The following is a description of a gene set: The process whose specific outcome is the progression of sensory organs over time, from its formation to the mature structure. Mouse Gene Set: GOBP_SENSORY_ORGAN_DEVELOPMENT studied in species Mus musculus, and this is the list of marker genes: Rrm1, Egfr, Inhbb, Gja1, Mfap2, Wnt10a, Limk2, Acvr2b, Prss56, Ftx, Hoxa13, Pax8, Dlx1, Krt13, Slc38a8, Abi2, Bfsp1, Agtpbp1, Mfap5, Tbc1d32, Sox4, Dicer1, Chrdl1 (chordin-like 1), Mir218-1, Tomt, Pbx4, Bcar3, Jmjd6, Frem2, Hpca (NCBI Gene Id 15444), Smoc1, Tulp1, Ift172, Gjb6, Prrx2, Kcnma1, Bloc1s5, Dll4 (NCBI Gene Id 54485), Igf1, Bcl11b, C1qtnf5, Dll1 (NCBI Gene Id 13388), Pax4 (NCBI Gene Id 18506), Dvl3, Tcap, Scrib, Mfrp, Tcf15, Wnt5a, Grhl3, Kdr, Fgf10, Pcdh15, Rd3, Bmp7, H2-T23, Lrig3, Hand2, Mafb, Tifab, Rpgr, Foxf2, Spred3, Rpl38, Pou4f2, Slc1a1, Ptf1a, Gli2, Lhfpl5, Prdm1, Lin7a, Tshr, Adam10, Blvra, Alms1, Lhx1 (NCBI Gene Id 16869), Itga8, Cdkn1c, Ttc39c, Vhl, Barhl2, Hoxa2, Sp3, Lamc3, Hmx3, Rpe65, Hsf4, Pdzd7, Ski, Kcnq4, Myo15a, Fzd2, Gjb2, Gdf11, Otogl, Mks1, Aqp1, Crygn, Foxc1, Thrb, Tfap2b, Ptprq, Nipbl, Tmod1, Nkx2-6, Gje1, Megf11, Nrl, Vax1, Chrna10, Tub, Olig3, Naglu, Slc26a5, Rubie, Gsdme, Neurog1, Rp1l1, Rarg, Usp45, Tspan12, Col4a1, Foxl2, Neurod4, Hcn1, Ptn, Cldn19, Calb1, Foxg1, Spry1, Epha2 (Eph receptor A2), Mitf, Klf4, Elmod3, Rorb, Tprn, Otx1, Slc17a8, Ihh, Ptpn11, Alg10b, Myo7a, Apc, Zfp513, Arhgap35, Ripor2, Gsc, Tgif1, Phactr4, Lgr5, Cntf, Cryba4, Hey2, Mapk1, Ift27, Bsg, Ccm2, Atp8a2, Foxn4 (NCBI Gene Id 243222), Slc25a25, Epha4, Rbpj, Gata2, Cys1, Gfi1, Mir23a, Miat, Nectin3, Edn1, Ror1, Fgfr1, Nkx2-5, Maf, Casp2, Hipk1, Mycn, Krtap21-1, Ift140, Adamts18, Clrn2, Fjx1, Myo3a, Ikzf1, Phox2b, Unc45b, Cryab, Pitx2, Abcb5, Irx5, Whrn, Jag2, Notch1, Mip, Hes1, Ush2a, Grn, Crygb, Cyp1a1 (NCBI Gene Id 13076), Sdk1, Smarcd3, Bhlhe22, Mir24-1, Prrx1, H2-DMa (NCBI Gene Id 14998), Nphp1, Mterf4, Kdm5b, Pde6a, Nphp4, Fasl, B9d1, Slc17a6, Yy1, Bmper, Rpgrip1l, Tfap4, Frzb, Chd7, Pde6b, Cryga, Sox1, Ptprm, Samd7, Foxp2, Irx6, Six5, Trpm1, Gnb1, Pdgfra, Rest, Gpd2, Hmx2, Grxcr2, Atp2b2, Scaper, Pou3f4, Sobp, Tmem231, Impg2 (interphotoreceptor matrix proteoglycan 2), Ifi204, Atf4, Gabra5, Pou2f1, Vegfa, C1qb, Atp2b4, Crybg3, Mfsd8, Pxdn, Gngt1, Gata3, Smg9, Jag1, Igfbp7, Plppr4, Hoxa1, Eya1, Myh10, Spry2, Fkbp8, Ret, Pcnt, Birc7, Efemp1, Pde6c, Bhlha15, Nhs, Ndp, Crygd, Pax6, Get1, Casz1, Wdpcp, Rxra (retinoid X receptor alpha), Atoh1, Man2a1, Dlx5, Bcl2l11, Insig2, Crb2, Nfia (nuclear factor I/A), Neurog3, Tbx18, Bmpr2, Skil, Psen1, Fbn1, Atoh7, Ntf5, Drd2, Crybb3, Wnt1, Arl6, Kcnk2, Fat4, Mertk (NCBI Gene Id 17289), Bmp5, Spag6l, Cecr2, Minar2, Vax2, Ankrd24, Cdh23, Cln8, Tgfb2, Cdh1, Per1, Gabrb2, Crygs (NCBI Gene Id 18384), Acvrl1, Prom1, Tgif2, Aldh1a3 (aldehyde dehydrogenase family 1, subfamily A3), Wt1, Zic1, Slc6a3, Foxc2, Atf6, Cacna1s, Cacna1c, Slc44a4, Ttc8, Ppp2r3a, Crx (NCBI Gene Id 12951), Nkx3-2, Aldh1a2, Lpcat1, Bbs10, Ephb2, Hpn, Kmt2c, Prdm16, Gabrr2, Arid1a, Prph2, Actl6a, Lhx2, Crygc, Olig2, Mir218-2, Dcx, Gng8, Hes5, Rara, Fgf20, Fgfr2, Pknox1, Pbx2, Dvl1, Slitrk6, Strc, Mir183, Gdf3, Intu, Clic4, Dchs1, Lctl, Ephb1 (NCBI Gene Id 270190), Tcirg1, Twist1, Bcl2, Spred1, Mdm1, Tfap2a, Dscam, Zeb2, Th, C3, Ints15, Lrig1, Gas1, Mcm2, Ctns, Pfdn5, Stat3, Pi4kb, Tulp3, Dlx2, Fos, Tdrd7, Rdh13, Lif, Xrn2, Grm6, Krt12, Sox11, Otop1, Cep290, Mab21l1, Foxi1, Ush1c, Meis3, Grcc10 (NCBI Gene Id 80671), Bbs1, Kera, Olfm3, Slc39a5, Nfix, Col11a1, Grin2b, Mpv17 (NCBI Gene Id 17527), Aqp5, Lama1, Sh3pxd2b, Dtnbp1, Med1, Vax2os, Ush1g, Rcn1, Ring1, Crb1, Tgfbr1, Gli3, Cdk20, Tgfb1, Bdnf (NCBI Gene Id 12064), Mir27b, Ntrk3, Rab18 (RAB18, member RAS oncogene family), Bcr, Six2, Flt1, Opn5, Bhlhe23, Fzd6, Dvl2, Rhoj, Trip11, Nf2, Mir23b, Lrp6, Stox1, Opn4, Osr2, Rpgrip1, Bmpr1b, Col5a2, Mir96, Six3, Ascl1, Tgfbr2, Myo3b, Samd11, Sox8, Notch2 (notch 2), Sp1, Fuz, Tmem135, Otx2, Gnat1, Enpp1, Fgf2, Dlg1, Sall2, Nes, Vangl2, Ednra, Oc90, Col5a1 (NCBI Gene Id 98940), Crygf, Lmx1b, Neurod2, Prkci, Bmp6, Nr4a3, Zhx2, Rarb, Fat3, Angptl7, Nox3, Zic3, Lef1, Rbp4, Nog (NCBI Gene Id 18121), Pds5b, Bfsp2, Meis2, Cryge (NCBI Gene Id 12968), Wdr19, Lrp10, Dram2, Neurog2 (NCBI Gene Id 11924), Chrna9, Wnt3a, Cxcl14, Fzd4, Vsx1, Tmc1 (transmembrane channel-like gene family 1), Slc4a7, Clrn1, Crybb2, Nrp1, Vstm4, Slc4a5, Hdac1, Smad3, Tbx1, Hdac2, Ahr, Grxcr1, Tsku, Ninj1, Sox2, Mir124a-2, Rab3gap1, Mab21l2, Arhgef15, Ahi1, Clcn2, Myo6, Otol1 (NCBI Gene Id 229389), Meis1, Zdhhc16, Otog, Pax5, Hif1a, Mfn2, Wnt10b, Tmem215, Insig1, Cryba2, Ccna2, Sox12, Ascl2, Cc2d2a, Ctnnb1, Neurod6, Cdkn1b, Kif3a, Bax, Hps1, Osr1, Bmp4, Nf1, Srf, Cebpd, Grhl2, Ift88, Twsg1, Thy1, Dlx6, Abr, Prkra, Ptk7, Prickle1, Pax2, Lhx3, Ocm, Nr2e1, Shh, Map3k1, Fzr1, Atg4b, Cthrc1, Fzd5 (NCBI Gene Id 98335), Inhba, Hmgb1 (high mobility group box 1), Hipk2, Cytl1, Poc5, Neurod1, Bloc1s3, Cdon, Fkrp, Rdh10, Nfib, Gja8, Serpinf1, Pdgfrb, Gsdma3, Bbs4, Elp6 (NCBI Gene Id 72341), Bnc2, Atp8b1, Six1, Cyp26b1, Eya4, Rho, Frs2, Celsr1, Msx1, Mir24-2, Myf5 (NCBI Gene Id 320915), Esrrb, Cebpa, Casp6, Ift122, Mycl (v-myc avian myelocytomatosis viral oncogene lung carcinoma derived), Pds5a, Sox3, Zeb1, Psap, Ror2, Rax, Hmgn1, Nectin1, Gnat2, Shroom2, H2-K1, Six6, Tmem132e, Anp32b, Plaat1, Lim2, Ddr1, Vim, Adamts9, Aldh1a1, Ttll5, Bmp2, Mir27a, Pou4f3, Myo7b, Atp6v1b1, Fat1, Hey1, Rpl24, Ntn1 (NCBI Gene Id 276903), Lamb2, Cnga3, Bak1, Clic5, Sipa1l3, Cabp4, Smchd1, Pbx1 (NCBI Gene Id 98516), Dzank1, Grk1, Ece1, B3glct, Col8a2, Col2a1, Traf3ip1, Tmie, Diaph3, Sdk2, Atg5, Mfsd2a, Tbx3, Myom1, Rs1, Adgrv1, Pdgfb, Hoxc13, Max, Gabrb3, Dio3, Cux1, Cryaa (crystallin, alpha A), Fgf9, Nr2e3, Cacna1f, Spred2, Stra6, Mir124a-1, Sco2, Mcoln3, Nherf1, Tecta, Col8a1, Pafah1b1, Pbx3, H2-T10, Jun (jun proto-oncogene), Gbx2, Sod1, Fscn2, Twist2, Cyp1b1, Tenm3, Sox9, Olig1, Arsg, Ache, Bbs7, Triobp, Fgf8, Prox1, Kcnq1, Kcnk3, Hesx1, Lrp5, Plaat3, Fzd3, Sos1, Cfh, Cited2, Duox2, Rom1, Fbn2, Pitx3, Sdc4, Sec24b, Pjvk, Mapkapk2, Sparc, Gpm6a, Cryba1, Myc, Vsx2, Ppp1r13l, Esrp1 (NCBI Gene Id 70076), Celf4, Kdm2b, Fgf3, Tshz1, Pls1, Ift20, Pygo2, Rp1, Rac1, Uchl3, Kit, Ntrk2, Cfd, Fgfr3, Six4, Mapk3, Crybb1, Tbx2, Foxe3, Slc7a11, Smarca4, Stau2, Mir182, Tbc1d20, Large1